Given this list of marker genes Gria1, Csmd1, Oprk1, Oprl1, Slc6a4, Slc1a1, Bdnf, here is a description of the gene set: species: Mus musculus The associative learning process by which an animal learns and remembers an association between a neutral, unchanging environment and a putatively rewarding, internal state produced by a xenobiotic or drug. Mouse Gene Set: GOBP_CONDITIONED_PLACE_PREFERENCE